The following is a description of a gene set: Mouse Gene Set: GOBP_POSITIVE_REGULATION_OF_SKELETAL_MUSCLE_TISSUE_REGENERATION studied in species Mus musculus Any process that activates or increase the rate of skeletal muscle regeneration., and this is the list of marker genes: Mir675, Sox15, Ppard, Hopx, Myod1, Capn3 (calpain 3)